Given this list of marker genes Ramp1, Calcr, Adm, Calcrl, Ramp2, Iapp, Adm2, Scn11a, Ramp3, here is a description of the gene set: Mouse Gene Set: GOBP_CALCITONIN_FAMILY_RECEPTOR_SIGNALING_PATHWAY A G protein-coupled receptor signaling pathway initiated by an extracellular member of the calcitonin family (e.g. adrenomedullin, adrenomedullin 2 (intermedin), amylin, calcitonin and calcitonin gene-related peptides (CGRPs)) binding to its receptor on the surface of a target cell, and ending with the regulation of a downstream cellular process. species: Mus musculus